The following is a description of a gene set: CD4(+)Foxp3(+) regulatory T (Treg) cells originate primarily from thymic differentiation, but conversion of mature T lymphocytes to Foxp3 positivity can be elicited by several means, including in vitro activation in the presence of TGF-beta. Retinoic acid (RA) increases TGF-beta-induced expression of Foxp3, through unknown molecular mechanisms. We showed here that, rather than enhancing TGF-beta signaling directly in naive CD4(+) T cells, RA negatively regulated an accompanying population of CD4(+) T cells with a CD44(hi) memory and effector phenotype. These memory cells actively inhibited the TGF-beta-induced conversion of naive CD4(+) T cells through the synthesis of a set of cytokines (IL-4, IL-21, IFN-gamma) whose expression was coordinately curtailed by RA. This indirect effect was evident in vivo and required the expression of the RA receptor alpha. Thus, cytokine-producing CD44(hi) cells actively restrain TGF-beta-mediated Foxp3 expression in naive T cells, and this balance can be shifted or fine-tuned by RA. species: Homo sapiens from publication Hill JA, Hall JA, Sun CM, Cai Q, Ghyselinck N, Chambon P, Belkaid Y, Mathis D, Benoist C (PMID 19006694) Genes up-regulated in regulatory T cell (Treg) treated with retinoic acid (tretinoin) versus conventional T cells. Human Gene Set: GSE13306_TREG_RA_VS_TCONV_RA_UP, and this is the list of marker genes: FDX1, FGF18, USP42 (NCBI Gene Id 84132), SLC12A9, BFSP2, USP43, DYNC1LI2, SCD, PNP, SHC1 (SHC adaptor protein 1), SCAMP1, MASTL, PLEKHO1, MBD5, NXPH2, KCTD20, NTRK1, IGF1, F2R, STX19 (syntaxin 19), FGF12, SMKR1, PFDN4, TMCO3, KLF2, COPRS, NUDCD3, RTKN2, MAMDC2, LONRF1, CAMSAP2, CD80, SLC44A2, ANTKMT, SMG8 (SMG8 nonsense mediated mRNA decay factor), GOLPH3, CAGE1, CSF3, EMC1, IKZF2, MED10, C19orf67, ABITRAM, ARHGEF2, RAB20, DDOST, NME6, FHAD1, MAST2, EFTUD2 (NCBI Gene Id 9343), COPZ2 (COPI coat complex subunit zeta 2), SLC12A2, CORT, PTPN11, GTF3C4, OGDH, MPI, ZNRF3 (NCBI Gene Id 84133), HSD11B1, C4orf51, BCL2, DOT1L, JPT2, LIPC, NKIRAS1, ALG3, S100A4, LARP7, UBE2D2, NIFK, VAMP1, PRPF31, YBX2, ATP6V1C1, JMJD8 (jumonji domain containing 8), DRG1, DNAJA4, ANKRD6, PDC, ANKS4B, EXO1, ITLN1, HOXA1, CDK10, IDE, LY6K, ACTG2, ENSA, CBL, POLR2J, DBI, TENM2, TXK, ZBTB37, JMJD4, CDH13, LIPN, MDFIC, SF3A2, RAD9A, PPP1R1A, HSP90AA1, UBE2L6, DNAJC30 (DnaJ heat shock protein family (Hsp40) member C30), TTC33, POU1F1, MAP1B, RTCA, FCER1A, TMEM119, H2AZ1, ARC, CCDC70, RAB40B, SHOX2, TNS2, WIPI2, AMBP, CCT6A, RPF1, RBM14, DRC1, CDIPT, PRDM10, INSIG1, BDKRB1, OMA1, PTPRB, HPF1, ZFP2, TMEM154, C19orf48P, DCUN1D5, CELSR2, TTC28, PRIM1, GABRG2, B3GNT6, ERP44, TXNRD2, SECTM1, TMEM248, FAM120AOS, YPEL2, DIAPH2, WDR83OS, NDFIP2, MAP4, GFAP, IZUMO1R, RBM25, ASCC1, MGAT4B, CDON, PROCR, UBE2Z, CSN2, KCNJ15, INS, ERMP1, ZNF623, OAT (ornithine aminotransferase), C1orf141, TRIP4, RRAGA, KIF27, NAALADL2, PLA2G12B, CXXC4, IRX2, DHX33, RPRM, REPS2, SOCS2, DCAF13, MMP3, DDI1, SPTSSB, CCDC88C, ADAMTS19, ARPC2, C18orf32, CNTNAP2, BCAP29, MST1R, KANSL1L, ADAM15, ORM2, GLT8D2, ELOVL6, MPZ, DHCR24, MDH1 (NCBI Gene Id 4190), SALL3, KIAA0232, CPNE2, NAT8L, LMNB2, HNRNPL, STOML2